Given this list of marker genes Cdh11, Rock2, Pcdha8, Phc1, Hipk3, Ints2, Fgf14, Glcci1, Helb, Ccnh, Bphl, Aadacl2fm1, Naa30, Psmd3, Pcdha7, Pcdha5, Amd2, Asph, Fundc1, Dnm1, Mtss1, Tpm1, Ctnnal1, Iws1, Xcr1, Ywhaq, Lmod1, Mmp8, Blvrb, Ptdss1, Cop1, Aebp2 (NCBI Gene Id 338513), Tomm70a, Wif1, Sbspon, Pcdha4, Arih1, Dync1li2, Wwtr1, Pcdha10, Pcdha6, Unc50, Cabp5, Cadm2 (cell adhesion molecule 2), Pcdha12, Rapgef2, Vim, Nek7, Sec24b, Rnf144a, Dmtn, Pcdha3, Pcdhac1, Ap1s2, Slc8a1 (NCBI Gene Id 319418), Pcdha11, Ctnnd2, Derl2, Ccdc148, D1Pas1, Kmt5b, Myh9, Anxa5, Pcdhac2, Chn1, Pcdha2, Vgll3, Ncam2, Itk, Neurod1, Kcna2, Igsf3, Zfpm2, Gpm6b, Pcdha9, Nr3c2, Pcdha1, Cnot2, Inpp5d, here is a description of the gene set: studied in species Mus musculus Genes predicted to be targets of miRBase v22 microRNA mmu_miR_127_5p in miRDB v6.0 with MirTarget v4 prediction scores > 80 (high confidence targets). from publication Chen Y, Wang X (PMID 31504780) Mouse Gene Set: MIR_127_5P